Given this list of marker genes CBLB, EIF4H, PKIB, RNF13, CDKN1A, WAS, ADAMTS2 (NCBI Gene Id 9509), SUMO1, TRIB1, CHUK, DNAJA1, IKBKB (NCBI Gene Id 3551), NIN, E2F4, DCTN2, CBX3, PCYT1A, LCMT2, ZNF653, DCLRE1B, SIN3A, IFI27L1, NDOR1, GALNT10, ZBTB3, ANKS1A, AKT2, FBXO22, FBXO28, FAM227B, HERC1 (HECT and RLD domain containing E3 ubiquitin protein ligase family member 1), DDX24, SNRPD2, NLK, APPL1, BCOR, FIZ1, SH3KBP1, ZCCHC9, AKT1S1, HSPE1 (NCBI Gene Id 82869), DHX30, GABARAP, TSEN54, PTCHD1, TBPL1, PAFAH1B2, CRK (NCBI Gene Id 1398), C1orf122, SOCS2, SUN2, UBXN6, YRDC, TGIF2, AP4B1, MADD, CAAP1, EXOC3L1, CNKSR1, TRAPPC11, ZBTB11, CASKIN2, ATP6V1G2, GABARAPL2, TERB1, ZNF79, DUSP6 (dual specificity phosphatase 6), HSPD1, ADSL, NOP53, CACNA2D2, SPRY2, GBA2, AMD1, TMEM203, MSANTD2, VPS13B, TMEM53, SPTY2D1, E2F5, ZNF524, MAP3K7, NEDD1, GSKIP, SYNJ1, SP3, NOC3L, FST, OTUD5, TAX1BP1, PUF60, EIF4A1, HCCS, AP4M1, CHERP, TBC1D22A, NRAS, SORBS3, SNRPC, DIABLO, NFKB2, BZW1, BAG6, TAF11, MOGS, TMUB2, TBC1D17, NRGN, CELF1, DTWD1, SRP14, ZER1, QPCTL, SERINC1, SND1, NFKBIL1, MCM7, RPE, GNG4, NAA60, HNRNPA2B1, RNF168, SF3B1, RGMA, RWDD4, here is a description of the gene set: from publication Xie X, Lu J, Kulbokas EJ, Golub TR, Mootha V, Lindblad-Toh K, Lander ES, Kellis M (PMID 15735639) Human Gene Set: GCGNNANTTCC_UNKNOWN Comprehensive identification of all functional elements encoded in the human genome is a fundamental need in biomedical research. Here, we present a comparative analysis of the human, mouse, rat and dog genomes to create a systematic catalogue of common regulatory motifs in promoters and 3' untranslated regions (3' UTRs). The promoter analysis yields 174 candidate motifs, including most previously known transcription-factor binding sites and 105 new motifs. The 3'-UTR analysis yields 106 motifs likely to be involved in post-transcriptional regulation. Nearly one-half are associated with microRNAs (miRNAs), leading to the discovery of many new miRNA genes and their likely target genes. Our results suggest that previous estimates of the number of human miRNA genes were low, and that miRNAs regulate at least 20% of human genes. The overall results provide a systematic view of gene regulation in the human, which will be refined as additional mammalian genomes become available. studied in species Homo sapiens Genes having at least one occurrence of the highly conserved motif M48 GCGNNANTTCC in the regions spanning 4 kb centered on their transcription starting sites. The motif does not match any known transcription factor binding site.